The following is a description of a gene set: Human Gene Set: GOBP_POSITIVE_REGULATION_OF_INTERLEUKIN_18_PRODUCTION studied in species Homo sapiens Any process that activates or increases the frequency, rate, or extent of interleukin-18 production., and this is the list of marker genes: GBP5, TNF, TLR2, NLRP9, USP50, CASP1, TLR9, DHX9, GSDMD